The following is a description of a gene set: studied in species Homo sapiens Generation of the male gamete; specialised haploid cells produced by meiosis and along with a female gamete takes part in sexual reproduction. Human Gene Set: GOBP_MALE_GAMETE_GENERATION, and this is the list of marker genes: CEP128, CCNO, DND1, AGO4, SIRT1, SPATA31C2, FSHB, PDILT, SPMIP7, AFG2A, SLC2A14, SLC26A6, PIWIL2, CFAP221, SLC22A16, SKIL, MSH4, LRGUK, PRSS21, CCDC146, SPATA31A6, CDYL, BPY2B, ADCY10, BPY2C, RNF8, YTHDC1, C2CD6, UBE2J1, SUN5, MLH1, SIAH1, FAM209B, SPEM3, PRKACA, CABS1, IFT20, BBS2, SEMG1, YTHDC2, CETN2, ELSPBP1, CDK16, SPEF2, GGN, UBB, DAZ2 (NCBI Gene Id 57055), ZNF449, SPATA31E1, GMCL2, AKAP4, HERC2, SYCE3, ATP2B4, MNS1, IFT56, ROS1, ATN1, ZNF628, LGR4, RNF17, SPO11, CATSPERD, CCDC63, GLI1, ADGB, SUN1, PANK2, DDX6, JAM2, PAX5, TUBA8, PGM3, ZMYND15, PATZ1, DDX25, CLDN11, CATSPER4, VPS54, RAD23B, CATSPERE (catsper channel auxiliary subunit epsilon), ADCYAP1R1, H1-1, ADAD2, CBY3, NR2C2, ACE, B4GALNT1, TMEM119, LRRC46, ZMYND12, LZTFL1, SPATA20, AP3B1, ROPN1B, CTSH, AFF4, CATSPER2, BAG6, ODF4, OR7C1, CIB1, DRC7, SPATA31A1, YIF1B, IMMP2L, KIAA0319L, SSTR1, SLC26A3, SOHLH1, SEPTIN12, CYLC2, SEMG2, SPATC1L, H3-3B, RAD51C, CHD5, TRIM27, SPANXB1, SEPTIN7, MROH2B, ARMC2, TDRD7, GMNC (NCBI Gene Id 652527), RARA, NR5A2, CFAP119, TXNDC8, TSNAX, SPATA31A5, EIF5A2, IQCG, CATSPER1, MYBL1, SYCP2, CFAP52, POC1A (NCBI Gene Id 25886), AGFG2, SPATA2, TSSK4, DAZAP1, DMC1, ATRX, IFTAP, DZIP1, E2F1, SPAG4, STRBP, PITHD1, KAT5, CCDC136, INSL3, HSF5 (NCBI Gene Id 124535), KRT9, SBF1, NPAP1, SCAPER, SPATA9, RHBDD1, ATP1A4, METTL14, CDY2A, BCL2L10, M1AP, TNP1, NANOS2, PAEP, CFAP91, TTC12, ZCWPW1, PRKACG, TBPL1, SPATA6, ZSCAN2, MEIG1, CFAP97D1, HROB, VPS13B, WFDC2, GARIN1A, SIX5, GMCL1, KDM3A, TSPY3, CFAP65, SLC25A31, NICOL1, SPMAP2, H1-6, ABHD2, RSPH6A, DAZ3, TESK2, ACTL7A, FAM9B, CATSPERG, CALR (calreticulin), PTTG1, TEX19, DPY19L2, PMCH, SPANXA1, SLC22A14, TLE6, PRSS42P, OCA2, TTLL8, VCX, ODAD3, SERPINA5 (serpin family A member 5), GK2, CFAP69, KASH5, ATM, TBP, TRIP13, PRM2, CREM, BCKDK, MEI4, ACVR2A, SOX9, HSF2, SMARCA2, LARP7, ADAD1, ROPN1, RSPH1 (NCBI Gene Id 89765), RIMBP3, ADAM28, IHO1, PLN, CCDC62 (coiled-coil domain containing 62), PRDX4, H1-7, HOXA9, CFAP206, MKRN2, ADAM7, ACSBG2, PFN4, REC114, MKKS, OSBP2, ACOX1, NOTCH1, TTLL5 (NCBI Gene Id 23093), DLEC1, FSIP2, CEP131, METTL3, RPL10L, HERPUD2, VIPAS39 (NCBI Gene Id 63894), NEURL1, TAF4B, IQCN, FNDC3A, ZNF541 (zinc finger protein 541), FOXJ3, PAFAH1B1, UBR2, MGAT4D, MAEL, MFSD14A, TSSK6, SELENOF, MLH3 (NCBI Gene Id 27030), SPA17, H2AX, PLEKHA1, BRDT, SLC19A2, UPF3A, CREB3L4, APOB, HSPA2, RBP4, SPINK1, NDC1, GGT1, ZPBP2 (zona pellucida binding protein 2), DNMT3A, TTLL3, ARID4B, WDR33, RAI14, CYLC1, TDRD5, IGF2R, TSPY2, CFAP43, PCSK4, CFAP157, TSSK1B, FKBP6, MSH6, SPINK2, CCDC42, RIMBP3C, FOXJ2 (NCBI Gene Id 55810), DNALI1, CFAP61, CRTAP, TBATA, ANKRD49, ADAM18, DMRTC2, MEIOC, SPAG8, IFT81, TDRD12, ADAM29, INHBB, PLA2G3, SOX17, BNC1, HERC4 (HECT and RLD domain containing E3 ubiquitin protein ligase 4), FBXO24, REC8, SPEM1, TESMIN, ACTL9, TXNRD3, MORN2, TSSK2, IFT25, CNTLN, ARID4A, MEIKIN, KNL1, H2BC1 (H2B clustered histone 1), FANCG, RBM46, ZBTB16, CFAP57, USP26, ASZ1, RGS2, AR, CATSPERB, WDR48, RFX2, LRRC8A, DAZ1, GPX4, KIT, GARIN1B, CCDC159, SUFU, SHISA6, CCNI, UBE2B, SPAG17, SPATA31A3, CDY1B, BTG1, GGNBP2, BCL2L11, LRRK2 (leucine rich repeat kinase 2), TMPRSS12, SPATA32, NME5, NLRP14, FAM209A, TYRO3, DHH, TSPY10, ODF1, SPAG11B, TMF1, DNHD1, DUSP13B, MAK, PIWIL3, TSPY9, BCL2L1, AXDND1, XRN2, SYNE1, SSX1, CIBAR1, ING2, KHDRBS1, FOXJ1, SLC26A8, CFAP53, SEPTIN6, ZPBP, FAM9C, TSPY8, PYGO2, DNMT3L, PRKAG1, ACRV1, CCNYL1, DHX36, DAZL, WIPF3, PMFBP1, GAL3ST1, SEPTIN2, GHSR, TTLL1, CCDC87, SPATA19, INPP5B, BCAP31, FANCA, LHCGR (luteinizing hormone/choriogonadotropin receptor), SPATA16, TCP11X2, OVOL1, TXNDC2, STRA8, DEFB118 (defensin beta 118), HOXA11, TBC1D20, DLD, YBX2, PIWIL1, HMGA2, MYCBP, MCMDC2, PCYT1B, BMAL1, ARMC3, SPAG16, FXR1, TEX15, JAG2, PROK2, DYNLL1, DDX4, ERCC1, SOX8, DAZ4, HMGB2, TOPAZ1, JAM3, C3orf62, TTC21A, ASF1B, SPATA22, ARMC12, FAM50A, CATSPERZ, OAZ3, SNRPA1, PRKG1, SFMBT1, PAFAH1B2 (platelet activating factor acetylhydrolase 1b catalytic subunit 2), RNF114, SGPL1, FSHR, RBX1, TAF1L, SEPTIN14, PSMA8, SPATA31C1, FIGNL1 (fidgetin like 1), MEIOB, PUM1, ADAMTS2, ADGRG2, SLCO4C1, MOV10L1 (Mov10 like RNA helicase 1), CLOCK, NPHP1, ARRDC5, CNTD1, CADM1, TMEM203, DNAH1, HSF1, SLC2A8, DNAAF3, SLIRP, TDRD6, BCL2L2, RB1, SYCP3, NANOS3, SLC9C1, CRKL, DEFB1, CT55, BTBD18, TSPY1, SPATA31D1, MAST2, CCNB1, SPATA31A7, TSSK3, GALNT3, PARP11, ELL3, TDRP, CNBD2, STK11, CDY2B, RIMBP3B, CCDC34, RBMY1B, KLHL10, IQCF1, C14orf39, BRME1, SASS6, BCL6, DPCD, AXL, SSH2 (NCBI Gene Id 85464), CUL4A, SPAG6, KCTD19, DRC1, SPACA1, SHCBP1L, MCM8, SOD1, H1-9P, HOATZ, NSUN2, PACRG, SPATA46, CABYR, PRDM9, TSNAXIP1, RPL39L (ribosomal protein L39 like), SPATA6L, SPANXA2, TSPAN8, BIRC3, SPMIP6, IFT27, CALR3, ZC3H14, MORC1, HOOK1, SPPL2C, USP9Y, VDAC3, PRM1, BSPH1, DPY19L2P2, FOXA3 (NCBI Gene Id 3171), BBOF1, PAFAH1B3, TARBP2, TEX11, KIF18A, TSPY4, TCP11X1 (t-complex 11 family, X-linked 1), YTHDF2 (NCBI Gene Id 63042), GALNTL5, RAN, CFTR, ZFY, BRIP1, DEDD (death effector domain containing), CCDC38, MERTK, ROPN1L, SLC4A2, CFAP44, NPR2, PHC2, NUP210L, CYP26B1, HADH, ETV5, BAX, TSGA10, PDCL2, TNP2, KIFC1, EPC1, ASPM, GORASP2, NDRG3, SYCP1, SMAD4, HORMAD1, NECTIN2 (NCBI Gene Id 5819), SPATA24, CFAP58, GJA1, CATSPER3, PSME4, BRD2, TBC1D21, ICA1L, ZNF35, UTP14C, SLC9A8, ZFP41, CIMAP1A, MEIOSIN, NR0B1, RNF151, NKAPL, BOLL, MYCBPAP, TDRD9 (NCBI Gene Id 122402), SPDYA, ZSCAN21, IZUMO3, QKI, ALKBH5, ATAT1, TESK1, DMRT1, ZNF296, PAIP2, TCFL5, KDM2B, TCP11, PIAS1, PNLDC1, FREY1, RUVBL1, PCDH11Y, ADAMTS16, SPATA31D3, CAPZA3, MCIDAS, H3-4, NEURL4, SPACDR, KATNAL1, TERB2, BPY2, SPATA25 (spermatogenesis associated 25), BBS4, STK33, ODF2, SOHLH2 (spermatogenesis and oogenesis specific basic helix-loop-helix 2), AGFG1, LIMK2, CCNY, TPGS1, ACRBP, CHN2, HSF2BP, CELF3, PGAM2, EFCAB9, FAM9A, SOX30, CDY1, CCNB1IP1, EIF4G3, SETX, HOXA10, ADIG, TP63, DCAF17, SEPTIN4, TPPP2, CCER1, CSNK2A2, MAJIN, TDRD1, NME8, TAF7L, GARIN4, TDRKH, PYGO1, KLC3, COX7B2, RACGAP1, CCIN, PLD6 (phospholipase D family member 6), CFAP47, MEA1, USP42, CFAP54, BRCA2, GTSF1 (NCBI Gene Id 121355), YBX3, PTCH1, GARIN3 (NCBI Gene Id 153745), NTRK1, GGNBP1, SPATA31D4, YY1, H3-3A, ZGLP1, PIWIL4, CCR6, CCNA1, EHMT2, AZIN2, PPP1CC, PRM3, TEX14, CEP57, SRPK1, POC1B, TMEM232, GAMT, SPOCD1